Given this list of marker genes FMNL2, MYO7A, MYL2, FAM222B, ERG, PPP1R21, OR4E2, CSTB, MFAP1, SH2B1, YWHAZ (NCBI Gene Id 83242), NCOA6, HRG, POU1F1, GAS7, ELOVL5, DAZAP2, CC2D1A, ARHGEF10L, ARHGEF4, ATXN1L, CLIP1, ZC3HAV1, CELSR3, HERPUD2, PAM, BMPR1A, NRBP1, SH3YL1, RALA, KIF5B, RAP1GDS1, COX8A (cytochrome c oxidase subunit 8A), GK5, OGFRL1, WNK2 (WNK lysine deficient protein kinase 2), CYP4A22, CORO7, PRKAR2A, FHIP2A, NIPAL4, WBP4, HIGD2A, MPC2, NDC80, CCHCR1, PAFAH1B1, NAP1L2, CEMIP2 (NCBI Gene Id 23670), FGL2, PPP2CB, SLC25A24, WDR47, CCDC88B, SFT2D1, SLC35G6, MYADM, AVPR1A, TUBA8, TNKS1BP1, CHAC1, SLC38A3, MED31, AP2A2, TRIOBP, FOXK1, RYR3, SLC37A3, NRDC, MCU, ADAMTSL3, BCKDK, STK38, SYCP1, ADPRH, UPF3A, TRIM36, MARK2, MAF1, PPP1R15B, PLA2G3, FOXD4L1, PLP1, SLC22A13, KMT2D, SPATA21, NDUFS5, STMP1, CHRNA9, AIM2, GPR35, ATG16L2, CITED2, KBTBD2, DSTYK, PRELID1, GNPDA1, MAPK8IP2, CCDC141, RHO, CARD6, BABAM1, GALM, NR5A1, TMEM86A, EZR, ATOX1, ACAP1, N4BP1 (NEDD4 binding protein 1), RAC1, TMEM252, LIMS4 (LIM zinc finger domain containing 4), SEMA4D, RNF146, LSR, GPR107, CXADR (NCBI Gene Id 95792), RIT1, TM6SF1, SNX13, WNT7B, C2orf68, SERPINA5, MED11, RARG, MSMO1, CTSS, SPOCK2, SLC6A12, MRPS18C, ATG3, STK10, NCOR1, TLR1, NCK1, CHRM3, FBXO10, USP12, PRKCD, CLEC5A, LDAF1, CYFIP1, B3GALT2, NDUFA6, SPIDR, KLF10, NR3C1, TTC17, SLC8B1, CSNK1E, WDR26, DCTN1 (NCBI Gene Id 82109), BANK1, ESCO2, MIR1915HG, MAP3K8, FAM217A, BICRA, ADORA3, CXCL3, RIGI, RAB1A, PTPRC, AK2, MMP24, GGNBP2, ARID3B, MCEE, CNR2, SLC44A2, ATP6V0D1, STIMATE, WIPI1, CASK (NCBI Gene Id 8573), USF2, RAC3 (Rac family small GTPase 3), PDLIM5, LAMC2, SLC25A2, VCF1, AXL, TAF8, IL18BP, SEPTIN7, ITPRIPL2, RTP4, ASNSD1, EHD1, TMCO3, PGGHG, MDM2, SRI, SLC25A20, FCGR2B, CLIC6, GJA5, MYO1H, GPR153, VPS13B, HAS2, here is a description of the gene set: from publication Konuma T, Nakamura S, Miyagi S, Negishi M, Chiba T, Oguro H, Yuan J, Mochizuki-Kashio M, Ichikawa H, Miyoshi H, Vidal M, Iwama A (PMID 21540074) Each fraction of mouse hematopoietic cells was purified by cell sorting from bone marrow of 8-week-old C57BL/6 mice, and its gene expression was analyzed. Human Gene Set: GSE27786_LIN_NEG_VS_MONO_MAC_DN species: Homo sapiens Genes down-regulated in comparison of lineage negative versus monocyte macrophages.